Given this list of marker genes ARSL, EBP, MGP, LBR, DDR2, here is a description of the gene set: Calcification (abnormal deposits of calcium) in the tracheal tissues. Human Gene Set: HP_TRACHEAL_CALCIFICATION Tracheal calcification species: Homo sapiens